Given this list of marker genes Agtr1a (angiotensin II receptor, type 1a), Hmox1, Il6ra, Tgm2, Gja1, Mmp9, Mtor, Npy5r (NCBI Gene Id 234339), Foxj2, Foxp1, C3ar1, Id2, Map3k7, Ddx39b, Bmpr1a, Akt1, Pdgfd, Fgf9, Il18 (interleukin 18), Elane, Pdgfrb, Nampt, Egfr, Ereg, Pde4d, Pik3ca, Ddr2, Igf1r, Traf6, Irak1, Igf1 (NCBI Gene Id 320499), Fgfr2, Map3k5, Ccn4, Agt, Ccl5, Ldlrap1, Fgf2, Calcrl, Ptk2, Serpinf2, Hdac4, Tnf, Mef2d, Retn, Nqo2, Kcnn4, Gnaq, P2ry6, Akr1b1, Jak2, Adamts1, S1pr1, Frs2, Mfn2, Rbpms2, Gnai2, Hes5, Prkca, Cdh13, Aif1, Jun, Dnmt1, Smpd3, Tert, Il13, Thbs1, Myc, Ager, Zfp143, Htr1b, Mnat1, Orc1, Sulf1, Vegfa, Phb1, Camk2d, Egr1, Itga2, Hif1a, Pdgfb, Rps6kb1, Myd88, Nox1, Hbegf, Ppargc1a, Irak4, Bmp4, Alox12, Edn1 (endothelin 1), Abcc4, Tgfbr2, Tlr4, Xbp1, Mmp2, Cx3cl1, Nf1, Pak1, Nr4a3, Gnai3, Notch3, Hpgd, Skp2, Ern1, Grk2, Pik3r1, Il6, Ptgs2, Tgfb1, Src, Gsk3b, Igfbp5, Flt1, Myb, Shc1, Stat5b, Cyba, Stat1, Itgb3, Hmgcr, Ptafr, Mdm2, here is a description of the gene set: Mouse Gene Set: GOBP_POSITIVE_REGULATION_OF_SMOOTH_MUSCLE_CELL_PROLIFERATION Any process that activates or increases the rate or extent of smooth muscle cell proliferation. studied in species Mus musculus